The following is a description of a gene set: The chemical reactions and pathways resulting in the formation of an amide, any derivative of an oxoacid in which an acidic hydroxy group has been replaced by an amino or substituted amino group. species: Homo sapiens Human Gene Set: GOBP_AMIDE_BIOSYNTHETIC_PROCESS, and this is the list of marker genes: SLC25A15, ELOVL4, GSS, ACAT1, ST8SIA4, C20orf173, OTC, GAL3ST1, HTD2, FA2H, GGTLC1, DIP2A, ST6GALNAC5, SGMS2, NANP, ORMDL2, TECR, CERS6, B4GALT5, ELOVL6, FASN, B4GALT3, MLYCD, ACSBG2, DCAKD, ACSL1, ORMDL3, SLC1A1, GGT6, HACD1, GGTLC2, GCLM, PDHA2 (NCBI Gene Id 5161), NANS, ZNF750, DEGS1, PLA2G6, PPCDC, PANK1, PANK3, SPTLC3, ASS1, ST3GAL1 (NCBI Gene Id 6482), ST3GAL2, ARG2, B4GALT4 (beta-1,4-galactosyltransferase 4), CHAC2, GCDH, ACSBG1, CBR4, PDK1, PRKAA1, B4GALT6, ASMT, GGTA1, ACSF3, CHAC1, PPT2, NAGS, ELOVL2, AANAT, AGMAT, PDK3, CCN1, SNCA, OSBP, SLC1A2, COASY, SMPD2, ST8SIA2, GGTLC3, PAM, ALOX12B, PDHB, SPTSSB, ASAH2, HAGH (hydroxyacylglutathione hydrolase), CARNS1, PM20D1, CYP4F22, PDHA1, BCKDK, ARG1, CLN8, PANK2, GGT3P, SLC25A2, PPT1, VAPA, HSD17B12, ACSL5, MECR, ACACB, GNE, PDK4, ACSL4 (NCBI Gene Id 4426), SLC27A2, ST6GALNAC4, ST8SIA3, DLAT, SIRT3, ELOVL5, GCLC (glutamate-cysteine ligase catalytic subunit), DEGS2, ACLY, PRKCD, ELOVL7, B4GALNT1, B3GALT1, SGMS1, BLOC1S6, GGT2P, CERS5, ASL, CERS4, ACSS2, ACSL6, PDHX, GGT1, AGK, SLC7A11, UGT8, SMPD4, GGT7, P2RX7, SPTLC1, B3GALT4, ST3GAL3, PNPLA1, ST6GALNAC3, ELOVL3, CERS2, ALOXE3, SPTLC2, PANK4, PPCS, HACD2 (NCBI Gene Id 9199), SAMD8, TPK1, GBA1, ENPP7, PGK1, ASNS, CEBPA, DLD, FH, ACOT7, TLCD3B, P2RX1, UGCG, MPC2, ST6GALNAC6, ACSL3, CERS1, NFE2L2, SPHK1, PDK2, ELOVL1, ACACA, PEMT, GGT5, CERS3, ABCA8, SPHK2, ST8SIA6, MGST2, ACSS1, ORMDL1, ASAH1, PAQR4 (progestin and adipoQ receptor family member 4), CPS1, ST3GAL5, SMPD1, B3GALT2 (beta-1,3-galactosyltransferase 2), MMUT, SPTSSA (NCBI Gene Id 171546)